The following is a description of a gene set: species: Mus musculus Mouse Gene Set: GOCC_AGGRESOME An inclusion body formed by dynein-dependent retrograde transport of an aggregated protein on microtubules., and this is the list of marker genes: Eef2, Psap, Rangap1, Slc2a3, Hspa1b, Dvl2, Eps15, Sqstm1, Urb2, Trim37, Sfmbt2, Stradb, Prkn, Tdp2, Pold1, Hoxd3, Xrn2 (NCBI Gene Id 24128), Klhl14, Ubd, Trim50, Card14, Ubqln1, Rnf32, Fgr, Hspa1a, Klf8, Psen1, Hspb7, Prkcq, Cabin1, Clu, Hoxc9, Edem1, Prdm16 (PR domain containing 16), Hdac6, Zbtb14